Given this list of marker genes SMC1A, NIPBL, PDS5A, SMC3, MAU2, STAG2, WAPL, RAD21, PDS5B, STAG1, here is a description of the gene set: part of: Mitotic Telophase/Cytokinesis In mitotic telophase, as chromosomes decondense, cohesin complex associated with PDS5 (PDS5A and PDS5B) and WAPAL (WAPL) proteins is loaded onto chromatin. Cohesin loading is facilitated by the complex of NIPBL (SCC2) and MAU2 (SCC4) proteins, which constitute an evolutionarily conserved cohesin loading complex. MAU2 depletion in HeLa cells results in 2-3-fold reduction in the amount of cohesin in the chromatin fraction. NIPBL mutations are the cause of the Cornelia de Lange syndrome, a dominantly inherited disorder characterized by facial malformations, limb defects, and growth and cognitive retardation. Cornelia de Lange syndrome can also be caused by mutations in cohesin subunits SMC1A and SMC3. studied in species Homo sapiens Reactome Pathway: Cohesin Loading onto Chromatin